The following is a description of a gene set: species: Homo sapiens Human Gene Set: GOBP_FOREBRAIN_NEURON_FATE_COMMITMENT The process in which the developmental fate of a cell becomes restricted such that it will develop into a neuron that resides in the forebrain., and this is the list of marker genes: ASCL1, GATA2, ZDHHC16, NKX2-1, PAX6, FEZF2, TBR1, BCL11B, TFAP2C